The following is a description of a gene set: species: Homo sapiens Thyroid carcinoma The presence of a carcinoma of the thyroid gland. Human Gene Set: HP_THYROID_CARCINOMA, and this is the list of marker genes: CDKN1A, TP53, CASP10, WRN, CDKN1B, SOX4, SEC23B, SDHB, SDHC, FOXI1, DPF2, FAS, CDKN2A, MDM2, NRAS, ARID2, BMPR1A, CDC73, SMARCE1, ARID1A, FOXE1, SOX11, SMARCD1, DICER1, HRAS, KCNJ10, KLLN, SRGAP1, PIK3CA, CHEK2, JAG1, HABP2, NF1, HEPACAM, RET, CDKN2B, USF3, PRKAR1A, SMARCA4, GREM1, SMARCB1, FLCN, KEAP1, SLC26A4, MEN1, NKX2-1, SMARCC2, SDHD, ARID1B, PRDM10, PTEN, CDKN2C, PDE11A, MINPP1, TG, APC, AKT1, FASLG